The following is a description of a gene set: Human Gene Set: GOBP_CAMP_BIOSYNTHETIC_PROCESS species: Homo sapiens The chemical reactions and pathways resulting in the formation of the nucleotide cAMP (cyclic AMP, adenosine 3',5'-cyclophosphate)., and this is the list of marker genes: ADCY9, ADCY10, ADCY2, ADCY1, ADCY7, ADCY4, ADCY3, ADCY5, ADCY6, ADCY8